Given this list of marker genes STX7, TMEM59, VPS4A, EPHA2, ANXA13, VAMP4, WNK3 (WNK lysine deficient protein kinase 3), TMED2, DLG1, PRKCE, SIRT6, WNK1, CNST, PICALM, IFNG, BCL2L1, PRKCH, SFN, ITGB1, PPFIA1, NUMB, MMP14, PLS1, TGFB1, PRKCI, NKD2, LYPLA1, LRP1, GBP1, LGALS3, MRAP, CDK5, PPP1R9B, STAC2, EZR, TREM2, PRNP, CSRP3, EPHB2, LDLRAP1, RSC1A1, ABI3, PIK3R2, AKT1, NHLRC1, LYPD1, EGFR, ACTB, STX8, PKP1, LRRC15, CLIP3, AR, SPTBN1, PDPK1, ZDHHC7, AP2M1, MRAP2, ZDHHC8, CAMK2G, CLN3, WNT3A, CAMK2A, WNK4, COMMD1, NRXN1, DAB2, RAB11A, CNPY4, DPP10, PTPN9, PPP2R5A, STX3, KIF5B, ITGA3, CSK, PIK3R1, SORBS1, ATP2C1, AGR2, ACSL3, TMBIM1, SQSTM1 (sequestosome 1), AKAP5, RAB11FIP2, RHOQ, RER1, EPM2A, ZDHHC2, RHOG, PID1, EPHA3, ARHGEF16, ARF6, STAC, CAMK2B, VTI1B, INS, CIB1, ATP2B4 (ATPase plasma membrane Ca2+ transporting 4), RAMP3, STAC3, RANGRF, PKDCC, GRIPAP1, VAMP8, APPL1, RACK1, CLTC, PGRMC1, STX4, ARHGAP44, CAMK2D, TNF, ZDHHC5, GPER1, MIR223 (NCBI Gene Id 407008), VIL1, LYPLAL1, here is a description of the gene set: Human Gene Set: GOBP_REGULATION_OF_PROTEIN_LOCALIZATION_TO_PLASMA_MEMBRANE Any process that modulates the frequency, rate or extent of protein localization to plasma membrane. studied in species Homo sapiens